The following is a description of a gene set: Human Gene Set: WILLIAMS_ESR2_TARGETS_DN from publication Williams C, Edvardsson K, Lewandowski SA, Ström A, Gustafsson JA (PMID 17700529) Transcriptional effects of estrogen result from its activation of two estrogen receptor (ER) isoforms; ERalpha that drives proliferation and ERbeta that is antiproliferative. Expression of ERbeta in xenograft tumors from the T47D breast cancer cell line reduces tumor growth and angiogenesis. If ERbeta can halt tumor growth, its introduction into cancers may be a novel therapeutic approach to the treatment of estrogen-responsive cancers. To assess the complete impact of ERbeta on transcription, we have made a full transcriptome analysis of ERalpha- and ERbeta-mediated gene regulation in T47D cell line with Tet-Off regulated ERbeta expression. Of the genes and transcripts analysed, 4.1% (1434) were altered by ERalpha activation. Tet withdrawal and subsequent ERbeta expression inhibited the ERalpha regulation of genes and, in addition, altered expression of 152 non-ERalpha-regulated genes. ERalpha-induced and ERbeta-repressed genes were involved in proliferation, steroid/xenobiotic metabolism and ion transport. The ERbeta repressive effect was further confirmed by proliferation assays, where ERbeta was shown to completely oppose the ERalpha-E2 induced proliferation. Additional analysis of ERbeta with a mutated DNA-binding domain revealed that this mutant, at least for a quantity of genes, antagonizes ERalpha even more strongly than ERbeta wt. From an examination of the genes regulated by ERalpha and ERbeta, we suggest that introduction of ERbeta may be an alternative therapeutic approach to the treatment of certain cancers. species: Homo sapiens Genes uniquely down-regulated in T47D cells (breast cancer) by induction of ESR2 expression in the Tet-Off system., and this is the list of marker genes: TAF1D, CBX5, MRPS16, SIPA1L2, TBL1XR1, ADM, S100A6 (NCBI Gene Id 6277), RPL21, EDN1, HMCN1, PANK2